Given this list of marker genes GPR65, WDR3, C15orf61, CCDC97, NOP2, RMND5B, CLEC10A, TEP1, SCN3A (sodium voltage-gated channel alpha subunit 3), CDH1, POLR3GL, MBNL1, RMND5A, PCM1, TXNDC16, DGKZ, CTNNA1, GADD45A, RB1CC1, PPP1R8, KIF5A, NCAPG2, C16orf54, INPP4A, URI1, PHETA2, MMS19, ME2, ARHGAP9, UCK2, PELI2, L1CAM, FAM217B, PTPRF, SPOP, CCDC117, MYBBP1A, MAP2K5, ATRX, ADI1, DNA2, YPEL3, ARHGAP45, SETX, C9orf85, NOC4L, FUNDC1, LRWD1, PTGER3, ABCC4, CDC42SE1, MARCHF1, MANBA, TNFAIP8L2, ORC4, RNF144B, SEPHS2, AKAP8, PTCD3, IDH2, ERP29, CALCOCO1, NFATC3, PTGER2, ADPGK, GATAD1, P2RY1, FRY, PLPP2 (NCBI Gene Id 8612), KANSL2, SDAD1, TIFA, SH2D5, FOXP1, CPPED1, CEBPA, KLK10, AKAP1, HASPIN, TCF12, EDEM3, FBXO32, ANKLE2, EHMT2, CDK20 (cyclin dependent kinase 20), SNHG3, GPR146, RIOK1, SPTBN1, CELF4, N4BP2L1, GPR180, ADNP, EIF4G3, PRKD2, CEACAM21, ZFP36L2, TIAM1 (NCBI Gene Id 7074), PPT1, ITGAE, C5orf24, EEF2K (eukaryotic elongation factor 2 kinase), CDKN2C, DPY19L1, RND3, OGT, DENND1B, OTULINL, CARS2, ZNRF3, RTN4RL1, CERS5, GTF2A2, PYCARD, PTPRS, IQGAP2, RASL11B, TVP23B, TNRC6B, NAAA, KLHL42, MRPS26, NUDT3, GRK6, KPNB1, GMNN, TCP1, INTS6L, INTS11, MIDEAS, DNMT1, ZMAT3 (NCBI Gene Id 64393), NFIC, UBAC1, STK17B, TOR4A, MIA2, RNF167, STAMBPL1, ZDHHC14, CCDC134, GCNT1, PACSIN1, DKC1, TRAF4, MADD (MAP kinase activating death domain), AHRR (aryl hydrocarbon receptor repressor), CCR2, CBX3, STK26, ADISSP, CRISPLD2, NUP153, C5orf34, PPP1R12C, IRF2BP2, NET1, SASH3, HES6, ABHD17A, RFX7, PGM2L1, MATN2, CENPI, ZBED4, PUM2, TAF4 (TATA-box binding protein associated factor 4), LTA4H, PAK1, ATP8B2, ERBB3, ABLIM1, SH2B2 (SH2B adaptor protein 2), SSH2, PIK3R2, SNX2, PACS2, RBFA, BMP2K, NCS1, XPA, EPS8, C8orf58, KLHL6, HPGD, ST3GAL4, CASP6, C2CD5, CCR9, GNE, BPGM, ARHGAP18, SCAP, RPS6KA1, IL6R, TNKS2, IFNAR2, SLC66A3, FOXRED2, HERC4, here is a description of the gene set: studied in species Homo sapiens Genes down-regulated in bone marrow-derived macrophages: interferon alpha versus IFNG. Human Gene Set: GSE35825_IFNA_VS_IFNG_STIM_MACROPHAGE_DN We used microarrays to compare interferon-alpha (IFNa)- and interferon-gamma (IFNg)-stimulated genes under an equivalent biological input. The goal was to compare IFNa- and IFNg-stimulated genes, as well as to identify common and distinct sets of type I and II ISGs. from publication Liu SY, Sanchez DJ, Aliyari R, Lu S, Cheng G (PMID 22371602)